Given this list of marker genes PCCA, MCEE, PHYH, PCCB, ACADS, PCK1, PCK2, here is a description of the gene set: species: Homo sapiens The chemical reactions and pathways resulting in the breakdown of a short-chain fatty acid. A short-chain fatty acid has an aliphatic tail containing fewer than 6 carbons. Human Gene Set: GOBP_SHORT_CHAIN_FATTY_ACID_CATABOLIC_PROCESS